Given this list of marker genes TBC1D8, MIR378D2HG, USP33, NIBAN3, PARK7, ZSWIM6, NUB1, MBNL1, TEC, PDSS1, EFL1, LIPT2-AS1, TCIRG1 (NCBI Gene Id 8845), NUDT1, USP38, PDXDC2P-NPIPB14P, TMEM147 (transmembrane protein 147), REEP4, CSTB, ACTL6B, ABHD11 (abhydrolase domain containing 11), PPP1R14A, FGFRL1, FBXL16, DPP8, U2SURP, ATOX1, SPPL2A, PKM (pyruvate kinase M1/2), MIF, APMAP, TACC3, KCNK5, DBP, PSMG1, RIPK1, TMEM18, STX16, ADAMTSL5, BTN2A2, ZNF594, ZFP64, MTG1, SLX9, ZNF638, PIDD1, ELMO2, DDX3X, IRF7, SLC25A43, LINC02028, SLC12A9, LIMS1, ARHGEF12, OTULIN, C15orf39, UNKL, PLOD1, TMEM177, EMD, SPHK2, PDIA3, SYCP2 (synaptonemal complex protein 2), PRSS27, SMIM29, KIAA0319, TCF25, RAB2A, APRT, HNRNPU, CCDC3, SPATA2L, CCNY-AS1, SLC12A9-AS1, TMEM39B (transmembrane protein 39B), ZNF18, AP1AR, ZNF213-AS1, SMAP1, PLA2G4E-AS1, PRODHLP, IDH3A, SVIL, DAG1, HSD11B1L, DYRK3-AS1, FLYWCH2, HAUS3, CDCA7, AHDC1, ZNF594-DT, CEP57L1, CARS2, CD99L2, CENATAC, MIR3659HG, ELOA, CACTIN-AS1, RN7SL521P, ODAD1, DCXR-DT, SF3B2, MON1A, SOAT1, BAHD1, SENP5, IL10RB, FYTTD1, BNIP2, ASH1L, PHF8, FAM241B, DEUP1, TTLL1, PURA, PACS1, PHF1, SYCE2, CNBP, MPHOSPH6, CCNQ, GAPVD1, ANAPC13, NR4A3, KPNB1, RPUSD1, MIR3190, DPYSL2, TCEA1, MBTPS1, CLN8, DANCR, TMEM135, MRPS2, TRAPPC9, C2orf68, MYDGF, FASTK, CCSAP, HABP4, RRBP1 (ribosome binding protein 1), LTO1, COL6A1, WRNIP1, NDUFAF6, NFE2L2, AP3B2, CDS1, MKRN1, TPCN2, CHGB, ASB1, PHF3, RAP2B, NAA50, CCNL2, C7orf25 (NCBI Gene Id 79020), ENSG00000223446, PLLP, EPS8L2, CLN8-AS1, NFATC3, RNASEH2C (NCBI Gene Id 84153), SLC25A12, PAQR9-AS1 (NCBI Gene Id 101927832), GALNT18, NAMPT-AS1, VAPB, SLC29A1, SLC25A1, PRKDC, CEROX1, P4HB, TXNDC11, DPH7, ZNF778-DT, ACADS, ALAD, PHYH, BRSK2, GMFG, FN3K, SARAF, HMG20B, ATP5F1D, SNAPC4, GFER, EFCAB13-DT (EFCAB13 divergent transcript), FIBCD1, TLCD4-RWDD3 (TLCD4-RWDD3 readthrough), PUM1, GEMIN8P4, EZR, LRRFIP2, HEXD, RPL36, VSIG10L-AS1, ENSG00000213963, ZNF367, NDE1, DGCR8, POU3F1, AK3, INKA2, SPIRE1, ZMYM5, SHMT1, MIR3171HG, DENND3, COSMOC, KCNH1-IT1, ZFTRAF1, SPRED1, SRRM2, PAXIP1, PIERCE1, SLC7A4, MGAT4B, SOX8, RPL35, ARID2, TRIM14, RCCD1, AFF4-DT, PPP2R2D (protein phosphatase 2 regulatory subunit Bdelta), SDF4, POLA1, ABCD1, RFX2, CRLF3, LINC00963, LINC00482, PDLIM2, CFL1, P4HA2, PEDS1-UBE2V1, NEK9, NELFA, MCM4, C2orf92, GCC2-AS1, TUBB4B, SLC25A13, POLD3, TMEM106B, ANO10, ZNF527, USP32, TSC22D2, TMEM123, LSM6, ENSG00000257346, CDKN2AIPNL, MAN2B1, PDCD6-DT, PIN1-DT, AMZ2, ITGAE, LAP3, VOPP1-DT, THAP8, TSPAN12, CPTP, TMEM14B-DT, PCYOX1, KAZALD1, LSM5 (LSM5 homolog, U6 small nuclear RNA and mRNA degradation associated), GPR107, IDI1, BRI3, AFF4, CABIN1, CCDC12, UBE3C, EMP2, MIEN1, SLC35A3, TMEM259, MVD, FMNL2, VPS9D1, RHBDD1, SLC25A28-DT (SLC25A28 divergent transcript), CRACR2A, RAB22A, PLCG1, TRIM7, TRMU, KIF17, FBH1, SPG7, UCK1, NF2, POLE4, TONSL, SPECC1L, IKZF1, TICAM2, MEF2A (NCBI Gene Id 4205), TMEM18-DT (TMEM18 divergent transcript), TECPR1, MPP7-DT, CPEB2, ITFG1-AS1, WDTC1, ARVCF, NECTIN2, HEATR5A-DT, SFR1, NBEAL2 (neurobeachin like 2), FZD5, ANKRD11, JMJD8, PDIA4, PPP3CC, FZD4-DT, CHSY1, OAT, DCXR, WDR83, PCBP2, APOO, RAB5IF, CDC42EP2, MAD2L2, IL18R1, LRRC37A5P, COX4I1, RBM33, MTHFS, TNIP2, POLR3C, PITRM1 (NCBI Gene Id 22910), RGS12 (NCBI Gene Id 6002), HEXB, NGFR, CEP63, SSH2 (NCBI Gene Id 85464), RPP38-DT, CHID1, NKIRAS2, STARD4, SCNN1G, YPEL1, GMEB2, ZHX1-C8orf76 (NCBI Gene Id 100533106), B3GALT6, PTCH2, ME2, SPCS1, GLT8D1, DNMT1, TUBB4A, ARRDC2, MRPL20, CSRP2, MACF1, ZHX1 (NCBI Gene Id 11244), STXBP2 (syntaxin binding protein 2, NCBI Gene Id 6813), DDX6, DRG1, PANK2, ETFB, EDF1, PGM2, FAM47E (family with sequence similarity 47 member E), CENPX, ENSG00000255647, LAMB4, LRRC27, ACSS2, SNORA26, TMEM9B, CRELD2, RNF103-CHMP3, WFS1, RMND5B, BMP8A, SUMO2, ZNF774, PDCD6P1, FAM131A, TMEM9B-AS1, LINC01385, GABRQ, CPSF1, ZNF593, TUBGCP5, LCORL, LSM7, PLCB2, DACT3-AS1, PCGF6, BLTP3B-DT, EMC8, GFOD3P, PAWRP1, WDTC1-DT, RCN2, REST, YRDC, STAG1-DT, MRPL38, OPRL1, FH, LINC01194, NDUFA5, TBCD, GFOD1, MTMR3, VSIG10L, TUSC2, POMGNT2, GIGYF2, MRPL20-AS1, ZZZ3, SNAI3-AS1, CLIC4, MOB3A, IMMT, GTF2IP13, CFAP184, FBXL2, ZNF852, LYL1 (NCBI Gene Id 4066), PANK4, ZNF318, PYGO2-AS1, IBA57, MTRES1, SEPTIN5, INPP5F, IRF1, GPR3, ZNF782, MEF2B, ERICH1, DHCR7-DT, PSMG2, ADD1, ASL, HSP90AA1, EFR3A, ZNF778, PTGES3L, LRRC59, MIR5695, AFTPH, EEFSEC, AVL9, C2CD2, DYRK3, GALK1, USP48, CATIP-AS1, NEURL2, TDP1, CAPN12, DBNDD2, PPARA, TANGO2, SF1-DT, TESC, ANAPC11, PROKR1, HPGD, LINC02166, ZNF653, ACBD7, MYO6, CTBP2, GSTZ1, TIMM29, ERF, MBTPS1-DT, SCARB2, KLF10, MAK16, VAPA, ARHGAP26, IER5L, ACSL4, MCM10, SLC7A6, DDX55, ATIC, MIR4515, TMEM129, ZNF558, TP53RK-DT, SMARCB1, QSOX1, PPP4C, MICOS13, CYFIP1, CARNMT1-AS1, CRACR2B, INCA1, MIOS, ZNF75D, NSMCE3, GAA, LINC01424, RRAS2, CNOT11, MPHOSPH6-DT, CPEB2-DT, MBD3L1, FARP2, USP30, CCDC18, PANX1, ZNF449, ZNF181, RASSF5, PROX1, PGS1, YWHAZ, DNM1, PHAF1, ZC3H14, RHBDF2, PDCD6, HMOX2, SLC2A8 (NCBI Gene Id 29988), PARP6, NFKBIE, NMRAL1, PTPN18, ASIC1, MSL3, SPOUT1, ABHD14A, MAP3K10, ZNF425, SLC38A10, RNASET2 (NCBI Gene Id 8635), STAT3, NLRX1, NBPF3, CYREN, GMPPB, LENG9 (NCBI Gene Id 94059), MCRIP2, TWSG1-DT, TRIM45, SRRM3, PRKRA, SMYD4, EFCAB13, GGA2, NTNG2, CPQ, CASTOR3P, ARPC5L, TMEM175, ANKRD12, CCDC112, PDP1, MRM2, GCN1, MALINC1, ITGB4, HTATIP2, ARHGEF1, MIB2, GLUD1, BMP8B, TLCD4, USP9X, LRRC45, FPGS, GAREM2, CD72, TP53TG5, DEPDC4, C21orf58 (NCBI Gene Id 54058), TMEM123-DT, SELENOOLP, GORASP1, SREBF1, TMEM104, MTFMT, TADA2B, KIF1B, RNU6-2, TMEM14B, LIPT2, CCAR2, SOX12, TMEM19, LMF1, GLRX2, LRWD1 (leucine rich repeats and WD repeat domain containing 1), ENO3, MAP3K7, KIF1C, HIRA, ENSG00000261798, PRKCB, JPT2, PANK2-AS1, RIC8A, GPSM2 (NCBI Gene Id 29899), FRG1, LTBP2, ENSG00000273828, TOR2A, NECAB3, CLCN7, EXOSC4, CRKL, NUDT4, PRPSAP1, STMP1, NAAA, TRIM7-AS2, ALYREF, MRFAP1P1, RANBP1, NNT-AS1, PRMT3, WHSC1L2P (NCBI Gene Id 83645), MIR4434, PHETA1, CERS2, PFN1, MMP24OS, LINC01301, PEDS1, RGS9, RBM33-DT, SNRPA1-DT, NPC1, PDK3, LINC01962, KCNH4, TMEM147-AS1, OGFOD3, AGPS, WDR37, LINC02352 (NCBI Gene Id 102725022), C9orf78, BHLHE40, PYGO2, KCNH1, TUBB2A, TUBG1, PSMD11, RAB11FIP1, SESN1, ZNF326, TPTEP1, NDUFV3, CAMK2G, ARHGAP31-AS1, ZNF706, ZSWIM7, STXBP1, TALDO1, USP20, GLRX3, KDM4B, TESC-AS1, BICRA, ACSL3, IMPDH1, SLC8A2, PKMYT1, ZNF517, SBNO2, GORASP2, POGLUT1, STK11, MIR5696, CDON, NAA40, WDR45B, PAQR9, ZER1, AFTPH-DT, FBXW2, TTC21A, FANCE, ACOT7 (NCBI Gene Id 11332), NEK7, SPIRE2, IP6K1, E4F1, WDR62, FOXO1B, SNRPA1, CIZ1, CATSPERD, TBXA2R, RAB40C, NMU, KISS1R, SAXO2, ABHD14A-ACY1, SUN1, ZBTB21, CCDC57, SLC1A5, CNNM3, BTBD1, RAB40B, SPECC1L-ADORA2A, TMEM70, CEBPG, PRPF19-DT, RUNDC1, MOB4, LINC01547, RPP38, SRRM2-AS1, METTL26, BCL2L1, RING1, PLEKHG4, NNT, SMYD5, CCDC138, ZNF212, IL10RB-DT, PSD, CHPF2, DECR2, RNF103, RBM20, STAG1, ZNF276, DNAJC10, MAN2C1, PIN1 (NCBI Gene Id 5300), PIP5KL1, MRPS28, USP38-DT, XYLB, TMEM39A, CDC14A, GLI4, PROCA1, SEC1P, TIRAP, PLEKHF1, SORBS1, LINC02356, WIZ, MTDH, FAM167A, E2F1, HACD1, SAV1, PTPRA, MBD6, SHFL, EIF2AK4, MRTFA, ALKBH4, CAPN1, CCNG2, EPAS1, TBC1D8-AS1, IZUMO4, ZNF786, ABCB10, SUV39H2-DT, MYH14, CENATAC-DT, ZNF837, ABHD14B, POMT2, SH3D21, CAPN1-AS1, CDKN2D, AK4, SECISBP2, TTC19, CDH15, AURKAIP1, FANCA, PPP4R3A (protein phosphatase 4 regulatory subunit 3A), RASL11B, SQSTM1, PHRF1, PCMTD1-DT, TBC1D5, THUMPD3-AS1, CTTN-DT, LRRC37A6P, USP14, PCCA-DT, SRSF6, AK6, KIFC2, ACTN4, HIBADH, BMAL1, SMS, RNPS1, PPM1H, MBOAT1, FADS3, POLN, TRAPPC2L, HLCS-AS1, RPS10P29, FHL2, ATXN1-AS1, MILIP, CLN6, NETO2, TBL2, MRPL40, TFAP2A, MAPKAPK3, LMNA, MARK3, HBEGF, SUCO, RUBCN, FAM174C (family with sequence similarity 174 member C), IKBKG, ZSCAN32, ATP6V1A, MON2, FHDC1, SEMA7A, CTTN, ABHD5, PJVK, SMTN, CEP76 (NCBI Gene Id 79959), TEF, MOCOS (molybdenum cofactor sulfurase), DMXL1-DT, REX1BD, EFCAB15P, SLC25A10, UPF3A, ACTR3C, BSCL2, COX17, C1orf216, MINK1, RCCD1-AS1, HPS3, TOR1B, DENND6B, YIPF2, HEYL, ORAI1, NHSL3, HADH, CDK2AP2, TTLL12, CYBC1, SF1, NECTIN1, PLIN2, POLR2B, NECTIN1-DT, MPZL1, RER1, STK32C, BCKDK, TICAM2-AS1, DENND3-AS1, HOXC-AS1, PPP2R5A, FRG1-DT, DMXL1, ANK1, NME4, LRP12, PCNT, MELTF, HMX3, ADRM1, ACAT1, CTSH, FADS1, PRIMPOL (primase and DNA directed polymerase), MICAL1, MAFG, PBX3, NAMPT, SMG1P5, RASGEF1B, ABL2, MYO5A, MIR4449 (microRNA 4449), CBLN1, LONP1, CDHR2, RALGDS, RNF38, HEATR5A, PIGS, PIEZO1, BRD7, EVL, CHCT1, FOXD3, PCMTD1, SURF1, PTGES3L-AARSD1, SCAP, PDXDC2P (pyridoxal dependent decarboxylase domain containing 2, pseudogene), GPAA1, RPLP2, ZNF775, SURF2, BICDL1, HTT, DACT3, ARFGAP1, C19orf73, EDC4, CTSA, ADAM15, TXNDC15, ANGPTL6, MLXIPL, FOXJ2, LINC02846 (long intergenic non-protein coding RNA 2846), AGPAT3, N4BP2, PPFIA3, ENSG00000267024, MCM9, FERMT2, TRMT2A, BAZ1A-AS1, SLC35C2, SGSM3, MATCAP2, COX5A, PYCARD, S1PR2, SLC35F2, ANXA11 (NCBI Gene Id 311, annexin A11), USP39, NCBP3, CECR7, TMED5, AP3D1, STRIP2, ENSG00000248783, LARP4B, ATP11A, HNRNPUL1, PGAP2, FOXK2, G6PD, CEP55, PDXDC1, NDUFV2, PLCD1, FBXO21, SLC16A6, TAF9, PHLDA1, ATG4D, MHENCR, GALNS, ACTR1B, TDH, SAMD4B, NUP98, AP1AR-DT, BCAP31, RN7SL525P (NCBI Gene Id 106480516), DOCK2, SUV39H2, RNF115, PWWP3A, NEDD1, MSL3-DT, PUF60, RCAN3, GTF2IP4, EHD2, MORN1, DHX30, CHTF18, B3GALT9, UBE2G2, MBD2, BEND3, F2R, AMACR (alpha-methylacyl-CoA racemase), TRIM28, TMCO1, ARPC1B, EGFL7, MRPL34, SAXO3, SEMA4F, ANKRD16, SETD5, FOXD3-AS1, SCMH1, CIB2, HDDC3, RAD17, CASP3, NAT9, DPP9, TDH-AS1, SLC7A5P1, KMT2B, LZTS2, LEPROTL1, NKAIN4, ARMH3 (NCBI Gene Id 79591), DPY19L4, FRMD8, DNAJC5, GATAD2A, UBA2, C11orf91, ALDH1A2, CAPRIN1, OPTN, ZNF77, CD55, ERCC6, C8orf88, E2F7, POLD2, PPP4R1L, ZNF398, IMPA2, NOD1, BICD2, SLC25A28, STMN3, KRI1, TTLL7, RPA1, NIPSNAP2, UNC93B1, CATSPER2P1, EHD4, NSFL1C, DHCR7, CARD19, RETREG3, TAFAZZIN, GAK, MKNK2, ZNF174, ARHGAP22, PPARD, SPPL2B, VOPP1, FGFR4, OTULIN-DT (OTULIN divergent transcript), SNAPC2, GABPB1-AS1, IL27RA, here is a description of the gene set: Human Gene Set: RBM34_TARGET_GENES from publication Yevshin I, Sharipov R, Kolmykov S, Kondrakhin Y, Kolpakov F (PMID 30445619) species: Homo sapiens Genes containing one or more binding sites for (RBM34) in their promoter regions (TSS -1000,+100 bp) as identified by GTRD version 20.06 ChIP-seq harmonization.